Given this list of marker genes XRCC1, APEX1, OGG1, NTHL1, PARP1, ADPRS, POLB, PARG, PARP2, here is a description of the gene set: Pathway Definition from KEGG: glycosylase -> APEX == POLB+XRCC1 == PARP,PARG,ADPRS Base excision and strand cleavage by bifunctional glycosylase. Pathway ID: N01434. Pathway type: Reference. Pathway class: nt06504 Base excision repair. studied in species Homo sapiens Human Gene Set: KEGG_MEDICUS_REFERENCE_BASE_EXCISION_AND_STRAND_CLEAVAGE_BY_BIFUNCTIONAL_GLYCOSYLASE